The following is a description of a gene set: Cytokines mediate cell-cell communication in the immune system and represent important therapeutic targets. A myriad of studies have highlighted their central role in immune function, yet we lack a global view of the cellular responses of each immune cell type to each cytokine. To address this gap, the authors created the Immune Dictionary, a compendium of single-cell transcriptomic profiles of more than 17 immune cell types in response to each of 86 cytokines (>1,400 cytokine-cell type combinations) in mouse lymph nodes in vivo. A cytokine-centric view of the dictionary revealed that most cytokines induce highly cell-type-specific responses. For example, the inflammatory cytokine interleukin-1β induces distinct gene programmes in almost every cell type. A cell-type-centric view of the dictionary identified more than 66 cytokine-driven cellular polarization states across immune cell types, including previously uncharacterized states such as an interleukin-18-induced polyfunctional natural killer cell state. from publication Cui A, Huang T, Li S, Ma A, Pérez JL, Sander C, Keskin DB, Wu CJ, Fraenkel E, Hacohen N (PMID 38057668) studied in species Mus musculus Genes positively differentially expressed in cell type: Monocyte upon treatment with cytokine: IL-33 in mouse lymph nodes in vivo. Mouse Gene Set: CUI_MONOCYTE_IL33_RESPONSE_UP, and this is the list of marker genes: Eif2s1, Fabp5, Naa25, Cltc, F10, Vcan, Tes, Naaa, Adam8, Eps8, Hspa9, Rbpj, Llph, Wdfy2, Gspt1, Ahr, Srm, Sdc4, Srsf7, Mrpl35, Eif3a, Cfp (NCBI Gene Id 18636), Ppa1, Nolc1, Nop58, Osm, Calr, Eif5a, Eif3g, Lilrb4b, Mrc1, Dok2, Batf3, Slfn2, Srsf2, Vrk1, Srsf3, Xbp1, Eif4e, Irf2bp2, Creld2, Ccl24, Cd44, Ccr5, Ccr1, Cd164, Arhgap31, Rsl1d1, Gda, Tsfm, Ctsz, Snx2, Fcgr2b, Arap2, Tfec, Tarm1, Cish, Lpxn, Manf, Selenos, Nop16, Ier3, Nsun2, Eif4a1, Cnbp, Casp6, Hspa5, Mydgf, Snrpf